Given this list of marker genes TMEM59, BRWD3, PURB, EGR2, C9orf72, STX12, GNB2, BACH1, BTBD7, BACH2, FNDC3A, KMT2A, IRAK1, ACSL4, TGFBR1, MARCKS, RAB40C, ADCY9, AFF2, RLF, MORF4L1, XPO1 (exportin 1, NCBI Gene Id 7514), CCNT2, MGAT4A, ARID5B, GFI1, APC, COL24A1, PSIP1, TARDBP, TFG, CSTF3, SLCO4C1, KAT7, TMEM132E, STAU1, RERE, TP53INP2, ROCK2, ADAMTS3, PDE4B, ANKS1A, SLC7A11, ZNF217, ATG16L1, HMGB1, TWF1, AKT1S1, MAP3K11, TRPS1, DCUN1D4, FNBP1L, ANK3, LCOR, STAM, SGK1, INPP5A, EDEM3, ATP2A2, TAOK1, RICTOR, TMEM200B, PPFIA1, SIK1, CLTA, S1PR3, SGMS1, HMGA2, CPEB2, PUM1, HECTD1, SMG1, SPIN1, TIPARP, LLGL2, SLC49A4, RAB2A, BAZ1A, STRN3, FBXO3 (F-box protein 3), UTY, MOB4, GNAQ, EML4, RAC1, KAT2B, SUCO, AFF1, ACVR2A, FMNL2, ZBTB41, TIRAP, LRRC1, ASB7, MMD (NCBI Gene Id 23531), COPS7A, VAMP3, SYPL1, SOX11, MBD6, SPRED1, PCGF3, RGL2, TAB2, PIP4P1, BOD1, SP8, FKBP1A (FKBP prolyl isomerase 1A), CFL2, CRK, FOXO4, CRTAM, COPG1, MORF4L2, ERG, ITGAV, SIK2, GTF2A1 (general transcription factor IIA subunit 1), PTPN23, EHF, ATF7IP, ARL15, ANKRD11, RARG, MRFAP1, PRLR, RNF31, BMAL1, KDM6A, BCLAF1, here is a description of the gene set: Genes having at least one occurence of the motif ACACTAC in their 3' untranslated region. The motif represents putative target (that is, seed match) of human mature miRNA hsa-miR-142-3p (v7.1 miRBase). Human Gene Set: ACACTAC_MIR1423P species: Homo sapiens